Given this list of marker genes Akt1, Rps6, Tnfaip6 (tumor necrosis factor alpha induced protein 6), Tm9sf5, Zfp830, Npr2, Ereg, Nppc, Bmpr1b, Ptx3, Amh, Gpr149, Ythdc1, here is a description of the gene set: species: Mus musculus Mouse Gene Set: GOBP_MAMMALIAN_OOGENESIS_STAGE A reproductive process that is a step in the formation and maturation of an ovum or female gamete from a primordial female germ cell.